The following is a description of a gene set: Pursed lips studied in species Homo sapiens An abnormality of the appearance of the face caused by constant contraction of the lips leading to a puckered or pursed appearance. Human Gene Set: HP_PURSED_LIPS, and this is the list of marker genes: MYH3, NALCN, LIFR, HSPG2, MYL11